The following is a description of a gene set: Human Gene Set: CREB_02 species: Homo sapiens Genes having at least one occurrence of the motif NNGNTGACGTNN in the regions spanning 4 kb centered on their transcription starting sites. This matches the CREB1 transcription factor binding site V$CREB_02 (v7.4 TRANSFAC)., and this is the list of marker genes: UBE2H (ubiquitin conjugating enzyme E2 H), THOC1, CAMK2D (calcium/calmodulin dependent protein kinase II delta), ALS2 (NCBI Gene Id 65058), USP48, GTF2H1, FBXL2, MED27 (mediator complex subunit 27), SRSF1, RNF166, ERC1, SREBF2, WNT10A, NUP98, CALM2, FDXR, ATG5, DDX28, XPR1, RPS29, SPRED2, RNF40, SIK1, DHX36, SSTR3, PRR3 (NCBI Gene Id 80742), RCE1 (NCBI Gene Id 9986), LYPD3, PHF20L1, DAD1, NKX6-1, CD2AP, TLNRD1, ZGRF1, TSC22D2, UMPS (NCBI Gene Id 7372), SART3, RBM18, GNL1, KDELR2, CNTROB, IVNS1ABP, SNAPC5 (small nuclear RNA activating complex polypeptide 5), CBLL1, SCFD2 (NCBI Gene Id 152579), ARIH1, CEP83, SLC35E1, PPP2R2A, ASPHD1, CDC14B, TMEM86A, ERLIN2, HS3ST3A1, IRX4, HNRNPAB, AKIRIN1, PRKCH, SLC30A5, POLDIP3, TCEAL9, ZNF23, PHF8, CTNND2 (catenin delta 2), CRH, PTPN23, ARMCX1, NF1, MMUT, RAB2A, RBKS, LGR5, GEM, JADE1, RAB25 (NCBI Gene Id 57111), SCAMP5, CCNI, RNF44, NR4A3, EPHA2, TSHZ2, YWHAZ (NCBI Gene Id 83242), SSNA1, AHR, KDELR3, FLT1, QRICH1, MMGT1, SCG2, EIF5A, BRMS1, PNMA3, PPM1A, MRM3, PELP1, PPARGC1A, MBNL2, CENPE, PDP1, MAGI1, USP36, ST13, TAGLN2, PCSK2, NOL4, TSPAN7, JADE2, ILRUN, ICE2, KICS2, IRF2BPL, PTGES3, ARTN, KDELR1, GLYR1 (NCBI Gene Id 84656), CDC42, UBE2D3, GTF2A1, DUS2, BRAF, MAP3K13, DHX40, NEUROD6, XPNPEP1, MRRF, TPT1, GRM3, TMEM39A, TIGAR, NOL10, ARMCX6, PLK4, ELL2 (elongation factor for RNA polymerase II 2), SGIP1, TIPRL (TOR signaling pathway regulator), PITX2, RUNDC3A, ODR4, SSBP3, LHX5, DUSP1, LMBRD1, THADA, ISCU, PAFAH1B1, IL1RAPL1, PPP1R15A, SNAP25, GPR3, LAYN, MAFF, HTN1, ZC3H18, VAMP2, FAM174A, RFC1, ZFYVE27, GTPBP10, YTHDC2, CLDN6, NINJ1, TPR, CHD2, SUCO, SEC24D, ZFAND5, MDN1, MAP1LC3A, H4C5, PRICKLE2, CENPQ, TRAPPC1, YTHDF3, RBBP8, BABAM2, HMGB1, KXD1, HHIP, ID1, C11orf87, TAOK2, TMEM59L, OSBP, FBXL19, BIN3, NOC4L, ZNF593, NR4A2, ANAPC2, PAK1, RIPOR1, NAPA, KPTN, GSC, HPS5 (HPS5 biogenesis of lysosomal organelles complex 2 subunit 2), POLB, BOD1L2, SOX12, RBP5, SULT4A1, PDLIM3, ZFY, XPNPEP3, SMARCAD1, SHKBP1, EEF2, KLHL12, ADAP1, SRP54, CLSTN3, AOPEP, FMC1, DDX51, SPAG9, JUND, RCAN1, VPS37B, ERF, IFT20, GLOD4, SDHB, CHGB, SNRPG (small nuclear ribonucleoprotein polypeptide G), DENND5A, SMARCA5, MRGPRF, CMSS1, SEMA3B, PHACTR3, CYLD, FOXD3, PNMA6A, CORO6, VPS37A, AGPAT1 (NCBI Gene Id 84827), RING1, SHANK2, TNFAIP1, TRMT10A, EVX1, DLST, GLI1, PCIF1, DCTN1, SAMD12, CNOT7, C5orf15, RNF5, SMARCD1, SLC20A2, NR2E1, UBA6, CLDN7, PAK3, HDAC6, SMS, ABHD16A, FOSB, ZFAND2B, TP53INP2